The following is a description of a gene set: Omega-9 fatty acid synthesis studied in species Mus musculus Mouse Gene Set: WP_OMEGA9_FATTY_ACID_SYNTHESIS, and this is the list of marker genes: Elovl1, Elovl5 (ELOVL fatty acid elongase 5), Acsl1, Fasn, Acot2, Acot1, Fads1, Scd2, Acsl3, Acsl4, Fads2, Elovl6, Elovl2, Elovl3